Given this list of marker genes GK3, LPIN2, LPIN1, MOGAT1, LPIN3, DGAT2, DGAT1, MOGAT3, MOGAT2, GPAM, AGMO, GK, GPAT2, GK2, here is a description of the gene set: Human Gene Set: REACTOME_TRIGLYCERIDE_BIOSYNTHESIS species: Homo sapiens Triglyceride biosynthesis